Given this list of marker genes Adora3 (adenosine A3 receptor), Adcy5, Oxgr1, Acp3, Necab2, P2ry12, Cntn2, Adora2a, Ada, Gnai2, Adora2b, P2ry1, Adora1, here is a description of the gene set: Mouse Gene Set: GOBP_G_PROTEIN_COUPLED_PURINERGIC_RECEPTOR_SIGNALING_PATHWAY A G protein-coupled receptor signaling pathway initiated by an extracellular purine or purine derivative binding to its receptor, and ending with the regulation of a downstream cellular process. species: Mus musculus